Given this list of marker genes Cacna1a, Cacna2d2 (NCBI Gene Id 56808), Cacnb1, Cacna1b, Cacnb2, Cacna2d3, Cacng2, Cacnb3, Cacna1e, Cacnb4, Cacng4, here is a description of the gene set: Mouse Gene Set: REACTOME_PRESYNAPTIC_DEPOLARIZATION_AND_CALCIUM_CHANNEL_OPENING Presynaptic depolarization and calcium channel opening studied in species Mus musculus